Given this list of marker genes DDX3X, EQTN, TBC1D32, CTSE, USP53, GML, TREM1, NAV1, FOXP1, MTM1, CD302, MGAT5, ABCA5, SRP19, XRCC4, NUDT12, CNOT6L, AMMECR1L, TLR3, FOXO3 (NCBI Gene Id 2309), MMP16, KRTAP19-3, CXCL13, PSMA5, RASGRP3, NDUFB3, SLC25A14, SYN2, CADPS2, CDKL3, DUOXA2, TMPRSS2, MEF2C, UBN2, MN1, PGK1, MYCBP2, CCSER1, C3orf18, TRPC1, CSNK2A2, CLXN, DZIP3, GP1BB, GRIA2, SERPINI2, MARF1, CTNND2, NDUFB11, OPRM1, RAB3GAP1, TRABD2B, WASHC4, SON, NMNAT1, MS4A18, LRRC3B, PTPRE, HLF, PTAFR, COX7A2, CA7, MPEG1, TIAM2, FBLN1 (NCBI Gene Id 2192), ATP5ME, SLC35D2 (solute carrier family 35 member D2), CREB1, ZNF292, ANKUB1, AGFG2, CCAR1, KIAA1549L, SYNJ2BP, ACYP2, THSD1, PNMT, CDH26, SYTL4, CDC20, ASB14, BRINP1, SNRPD2, COX6C, NMNAT2, NAALADL2, RPF2, MRPL20, CWC22, ALDH5A1, DYNLT1, CCDC3, NIPBL, TMEM181, TRIM60, GJD2, GABRB2, INSL5, ACER3, PAN3, NDUFA2, OTOS, PLPPR4, SERF1A, C2CD5, CHODL, BDNF, MMUT, NTHL1, MBNL2, KCTD18, TERB1, NCAM2, RIC3, LRRC69, CPA2, DRGX (NCBI Gene Id 648501), CLDN18, TRIL, HSD11B1, RPL26, MFAP1, CSDC2, LRATD1, RGMB, AIF1L, ATXN7L3B, CAPN6, COL4A1, MARCHF11, F8A1, OXGR1, LNX1, KCNN2, TSPAN32 (NCBI Gene Id 10077), GSX2, LAMTOR5, ENDOU, RAB39B, CTTN, ART3, FIBIN, FEN1, DNAH12, MAP3K2, MYOD1, AZIN2, MAT2A, TTC32, MBD5, PRKACB (NCBI Gene Id 5567), MFAP3, SLC26A7, WNT1, CEMIP2, PPTC7, GCFC2, PHIP, FANCD2OS (NCBI Gene Id 115795), KALRN, B3GAT2, BLTP3B, EPHA7, IL22RA2, NIPSNAP3B, ASPRV1, OCA2, C6, GAPVD1, ASB4, STEAP1, NQO1, MYRIP, SEMA3E, IL17RE, SPMIP7, ITGA6, LYRM9, TMEM45A, PEX11A, IGF2BP2, CYP3A4, ST18, PPP4R4, SPRR2A, CNGA2, TEX38, DEPP1, H2BC18, CD52 (CD52 molecule), NOCT, PIWIL1, EDIL3, ITGB1BP2, DZANK1, ELAVL2 (ELAV like RNA binding protein 2), ALPL, LSAMP, RBP7, MRPL33, here is a description of the gene set: from publication Szanto A, Balint BL, Nagy ZS, Barta E, Dezso B, Pap A, Szeles L, Poliska S, Oros M, Evans RM, Barak Y, Schwabe J, Nagy L (PMID 21093321) Genes down-regulated in monocytes versus macrophages. Human CD14 positive monocytes were purified from healthy volunteers’ blood and cultured in vitro for 4, 12, 24, 72 hours. While culturing, macrophages were activated alternatively with interleukin-4 (IL-4 100 ng/ml) or classically with interferon-gamma (IFNg 100 ng/ml)+tumor necrosis factor (TNF 50 ng/ml) or left without activation. Simultaneously, macrophages were also treated with vehicle (DMSO:ethanol) or 1mM synthetic PPARg agonist, Rosiglitazone. We used Affymetrix microarrays (U133Plus 2.0) to analyze activation and PPARg-induced gene expression changes. species: Homo sapiens Human Gene Set: GSE16385_MONOCYTE_VS_MACROPHAGE_DN